The following is a description of a gene set: species: Mus musculus Mouse Gene Set: GOBP_PURINE_NUCLEOSIDE_BIOSYNTHETIC_PROCESS The chemical reactions and pathways resulting in the formation of any purine nucleoside, one of a family of organic molecules consisting of a purine base covalently bonded to a sugar ribose (a ribonucleoside) or deoxyribose (a deoxyribonucleoside)., and this is the list of marker genes: Pnp, Adk, Adal, Pgm2, Mtap, Hprt1, Ada, Nt5e, Ak1, Aprt